Given this list of marker genes SART1, ZMYND8, CLDND1, SYT13, B2M, SERINC3, AFF3, CALR, SNRNP70, CAVIN2, here is a description of the gene set: Human Gene Set: SCHAEFFER_PROSTATE_DEVELOPMENT_AND_CANCER_BOX1_DN Early prostate development genes (down-regulated at 6 h dihydrotestosterone) which are also down-regulated in normal epithelium vs high grade prostatic intraepithelial neoplasia (PIN). from publication Schaeffer EM, Marchionni L, Huang Z, Simons B, Blackman A, Yu W, Parmigiani G, Berman DM (PMID 18794802) Cancer cells differentiate along specific lineages that largely determine their clinical and biologic behavior. Distinct cancer phenotypes from different cells and organs likely result from unique gene expression repertoires established in the embryo and maintained after malignant transformation. We used comprehensive gene expression analysis to examine this concept in the prostate, an organ with a tractable developmental program and a high propensity for cancer. We focused on gene expression in the murine prostate rudiment at three time points during the first 48 h of exposure to androgen, which initiates proliferation and invasion of prostate epithelial buds into surrounding urogenital sinus mesenchyme. Here, we show that androgen exposure regulates genes previously implicated in prostate carcinogenesis comprising pathways for the phosphatase and tensin homolog (PTEN), fibroblast growth factor (FGF)/mitogen-activated protein kinase (MAPK), and Wnt signaling along with cellular programs regulating such 'hallmarks' of cancer as angiogenesis, apoptosis, migration and proliferation. We found statistically significant evidence for novel androgen-induced gene regulation events that establish and/or maintain prostate cell fate. These include modulation of gene expression through microRNAs, expression of specific transcription factors, and regulation of their predicted targets. By querying public gene expression databases from other tissues, we found that rather than generally characterizing androgen exposure or epithelial budding, the early prostate development program more closely resembles the program for human prostate cancer. Most importantly, early androgen-regulated genes and functional themes associated with prostate development were highly enriched in contrasts between increasingly lethal forms of prostate cancer, confirming a 'reactivation' of embryonic pathways for proliferation and invasion in prostate cancer progression. Among the genes with the most significant links to the development and cancer, we highlight coordinate induction of the transcription factor Sox9 and suppression of the proapoptotic phospholipid-binding protein Annexin A1 that link early prostate development to early prostate carcinogenesis. These results credential early prostate development as a reliable and valid model system for the investigation of genes and pathways that drive prostate cancer. studied in species Mus musculus